The following is a description of a gene set: Reactome Pathway: Cellular response to mitochondrial stress part of: Cellular responses to stress studied in species Homo sapiens Mitochondrial stress caused by depolarization of the mitochondrial inner membrane, inhibition of proton flux across the mitochondrial inner membrane, or insufficient protein import capacity caused by inhibition of ATP synthase or iron deficiency is communicated to the cytosol and nucleus, resulting in decreased protein production and increased transcription of chaperones and metabolic genes among others. This pathway is known as the mitochondrial stress response and is a part of mitochondrial signaling and the integrated stress response (Reviewed in Eckl et al. 2021, Picard and Shirihai 2022, Lu et al. 2022, Liu and Birsoy 2023). The mitochondrial stress response participates in adapting cells to harsher environments and, hence, plays a role in tumor progression and metastasis.<br>In unstressed mitochondria, DELE1 is constitutively imported into the mitochondrial matrix and degraded by the LONP1 ATP-dependent protease. Mitochondrial stress inhibits the complete transit of DELE1 into the matrix and activates the inner membrane protease OMA1 by self-cleavage. Activated OMA1 cleaves the N-terminal region of DELE1 on the outer face of the inner membrane as DELE1 is unable to fully cross the inner membrane. The resulting C-terminal fragment of DELE1 egresses from the intermembrane space to the cytosol where it oligomerizes to form an octamer which binds and activates EIF2AK1, a constituent kinase of the integrated stress response that phosphorylates EIF2S1, the alpha subunit of the eukaryotic translation initiation factor 2 (eIF2). Phosphorylation of EIF2S1 inhibits general translation but increases translation of specific mRNAs that possess upstream open reading frames. Among these mRNAs are the transcription factors DDIT3 (CHOP), ATF4, and ATF5, which activate expression of chaperone genes among others., and this is the list of marker genes: YME1L1, EIF2S1, STOML2, DELE1, EIF2S3, OMA1, EIF2AK1, PHB2, EIF2S2